Given this list of marker genes ABT1, RPS6, AATF, NOB1, RPS25, RPS11, RPS21, NGDN, TSR1, SLX9 (NCBI Gene Id 91110), RPSA2, DCAF13, UTP18, MCAT, SNU13, PWP2, KRR1, LTV1, NAT10, RPS24, EMG1, NOL11 (NCBI Gene Id 25926), RIOK3, RIOK2, NOL6, PRKDC, MRPS7, RRP7BP, WDR36, ERAL1, WDR75, RPS23, BMS1, RPS4X, TRMT112, SRFBP1, ERCC2, TSR3, NOP58, RPS3A, RPS17, RIOK1, PNO1, RPS16, WDR43, BYSL, RPS8, UTP3, RPS12, RPSA, RPS9, NPM1, RPS15, FAU, FBL, NOL7, RRS1, UTP4, DNTTIP2, RPS19BP1, RRP7A, RCL1, LSM6, RPP40, RPS14, NOM1, DHX37, XRCC5, GTF2H5, EXOSC10, SURF6, RPS27A, TSR2, NOP56, UTP25, MPHOSPH10, FCF1, NOL10, KRI1, RPS27L, WDR46, RCC1L, NOP9, HEATR1, RPS13, AK6, RPS15A, METTL17, UTP23, DDX52, NOP14, RRP36, RPS27, UTP20, UTP15, WDR3, RPS5, RPS19, C1orf131, IMP3, RPS7, UTP11, RPS28, DIMT1, IMP4, TBL3, RRP9, UTP6, here is a description of the gene set: Human Gene Set: GOBP_RIBOSOMAL_SMALL_SUBUNIT_BIOGENESIS species: Homo sapiens A cellular process that results in the biosynthesis of constituent macromolecules, assembly, and arrangement of constituent parts of a small ribosomal subunit; includes transport to the sites of protein synthesis.